The following is a description of a gene set: studied in species Mus musculus Mouse Gene Set: GOBP_ENDOTHELIAL_CELL_PROLIFERATION The multiplication or reproduction of endothelial cells, resulting in the expansion of a cell population. Endothelial cells are thin flattened cells which line the inside surfaces of body cavities, blood vessels, and lymph vessels, making up the endothelium., and this is the list of marker genes: Eng, Pdcd10, Mir124a-1hg, Stat5a, Fut1, Lipa, Egr3, Bmpr1a, Hmgb1, Itga4, Htr2b, Wnt5a, Jcad, Acvrl1 (NCBI Gene Id 11482), Apela, Ccl24, Xbp1, F3, Col8a2, Hmox1, Tie1, Lep, Dysf, Ang, Vegfb, Ager, Igf1, Kdr, Mdk, Dlg1, Bmp6, Xdh, Apoa1, Agtr1b, Egfl7, Emc10, Nrarp, Sema5a, Nr4a1, Prkx, Fgfr3, Cav1, Ecm1, Pgf, Stat1, Tsc2, Dbh, Prok1, Tek (NCBI Gene Id 99999), Adora2b, Thap1, Tgfbr1, Flt1, Synj2bp, Atp5if1 (ATP synthase inhibitory factor subunit 1), Ang6, Stat3, Adam17, Plcg1, Aldh1a2, Nr2f2, Cxcl12, Cav2, Krit1 (KRIT1, ankyrin repeat containing), Mef2c, Nf1, Sparc, Loxl2, Pdpk1, Prox1, Fgf2, Prkd2, Prkd1, Jun, Apoe, Mmrn2, Aggf1, Sirt6, Egf, Zeb2, Ccl12, Pold4, Lrg1, Itgb3, Scarb1, Rptor, Gja1, Atp5f1a, Itgb1bp1, Dll4 (delta like canonical Notch ligand 4), Pdcl3, Vash2, Col4a3, Ghsr, Col18a1 (collagen, type XVIII, alpha 1), Pdgfb, Akt1, Akt3, Cd34, Fgfr1, Prok2, Flt4, Vegfa, Ghrl, Slc39a9, Atoh8, Sp1, Thbs1, Aimp1, Mtor, Pparg, Fgfbp1 (fibroblast growth factor binding protein 1), Thbs4, Ngfr, Pik3cd, Tnf (NCBI Gene Id 21926), Ptprm, Hmgb2, Fut2, Col8a1, Ccr3, S2bpcox16, Ang2, Scg2, Cxcr3, Hspg2, Agtr1a, Bmper, Il10, Nras, Tnmd, Rgcc, Sulf1, Apc, Apln, Pdcd6, Rictor, Bmpr2, Il12b, Mmp14, Apoh (NCBI Gene Id 11818), Zfp580, Cdh13, Sirt1, Il12a, Ang4, Ccl2, Alox5, Pla2g2a, Prkca, Cyba, Ppp1r16b, Vstm4, Arg1, Wnt2, Mydgf, Bmp4 (NCBI Gene Id 12159), Cnmd, Nppb, Ccl11, Plxnb3, Fgf10, Gata2, Enpep, Gdf2, Prl, Igf2, Aplnr, Ang5, Fgf7, Ccl26, Vash1, Ern1, Vip, Pik3cb, Dicer1, Dlk1, Epha2